Given this list of marker genes WDR26, PORCN, RAB3GAP2 (NCBI Gene Id 26114), TONSL, AMER1, here is a description of the gene set: Osteopathia striata Human Gene Set: HP_OSTEOPATHIA_STRIATA A lamellar pattern visible on radiographs and mainly localized at the metaphyses of the long tubular bones. Pathologic-anatomical studies revealed that these benign signs on x-rays are the result of a juvenile metaphyseal bone necrosis. Calcifications in the necrotic marrow lead to this lamellar or lattice-like appearance. species: Homo sapiens